Given this list of marker genes NODAL, BOK, ACVR1C (activin A receptor type 1C), INSL4, FZD5, here is a description of the gene set: Human Gene Set: GOBP_CHORIONIC_TROPHOBLAST_CELL_PROLIFERATION The multiplication or reproduction of chorionic trophoblast cells, resulting in the expansion of their population. studied in species Homo sapiens